The following is a description of a gene set: Human Gene Set: GOBP_POSITIVE_REGULATION_OF_DENDRITIC_CELL_DIFFERENTIATION Any process that activates or increases the frequency, rate or extent of dendritic cell differentiation. studied in species Homo sapiens, and this is the list of marker genes: LGALS3, AGER, ZBTB46, HMGB1, LGALS9, LGALS1